Given this list of marker genes CTSK, PCOLCE, FILIP1L, FBN1, FAP, COL3A1, COL5A2, SPARC, HTRA1, SERPINF1, ADAM12, THBS2, DACT1, COL1A2, SRPX2, COL5A1, AEBP1, NID2 (NCBI Gene Id 95183), CDH11, here is a description of the gene set: Human Gene Set: FARMER_BREAST_CANCER_CLUSTER_4 Cluster 4: selected stromal genes clustered together across breast cancer samples. Previous microarray studies on breast cancer identified multiple tumour classes, of which the most prominent, named luminal and basal, differ in expression of the oestrogen receptor alpha gene (ER). We report here the identification of a group of breast tumours with increased androgen signalling and a 'molecular apocrine' gene expression profile. Tumour samples from 49 patients with large operable or locally advanced breast cancers were tested on Affymetrix U133A gene expression microarrays. Principal components analysis and hierarchical clustering split the tumours into three groups: basal, luminal and a group we call molecular apocrine. All of the molecular apocrine tumours have strong apocrine features on histological examination (P=0.0002). The molecular apocrine group is androgen receptor (AR) positive and contains all of the ER-negative tumours outside the basal group. Kolmogorov-Smirnov testing indicates that oestrogen signalling is most active in the luminal group, and androgen signalling is most active in the molecular apocrine group. ERBB2 amplification is commoner in the molecular apocrine than the other groups. Genes that best split the three groups were identified by Wilcoxon test. Correlation of the average expression profile of these genes in our data with the expression profile of individual tumours in four published breast cancer studies suggest that molecular apocrine tumours represent 8-14% of tumours in these studies. Our data show that it is possible with microarray data to divide mammary tumour cells into three groups based on steroid receptor activity: luminal (ER+ AR+), basal (ER- AR-) and molecular apocrine (ER- AR+). species: Homo sapiens from publication Farmer P, Bonnefoi H, Becette V, Tubiana-Hulin M, Fumoleau P, Larsimont D, Macgrogan G, Bergh J, Cameron D, Goldstein D, Duss S, Nicoulaz AL, Brisken C, Fiche M, Delorenzi M, Iggo R (PMID 15897907)